The following is a description of a gene set: Human Gene Set: GNF2_RAP1B Neighborhood of RAP1B RAP1B, member of RAS oncogene family in the GNF2 expression compendium Neighborhood of RAP1B studied in species Homo sapiens, and this is the list of marker genes: HLA-G, ELF4, SCAF8, KDM5A, VPS16, RETREG3, STK38, IQGAP1, HLA-F, TUT7, RASSF1, GPR65, ACTR3, CYTIP, MAT2B (methionine adenosyltransferase 2 non-catalytic beta subunit), CLEC2B, HLA-E, ADGRE5, ADAM8 (NCBI Gene Id 101), RAC2, JAK1, ADAM10, SNX6, RAP1B, STK10 (serine/threonine kinase 10), PTPRC, BTN3A3, RAP2B, ADCY7 (NCBI Gene Id 113), MSN, ITGAL, BIN2, MBNL1, INPP5D, CAB39, OSTF1